Given this list of marker genes MIR125B1, HOXA7, CDK6, APCS, ZBTB46, GPR68 (NCBI Gene Id 8111), INPP5D, MYC, here is a description of the gene set: species: Homo sapiens Any process that stops, prevents, or reduces the frequency, rate or extent of monocyte differentiation. Human Gene Set: GOBP_NEGATIVE_REGULATION_OF_MONOCYTE_DIFFERENTIATION